The following is a description of a gene set: Genes predicted to be targets of miRBase v22 microRNA mmu_miR_23b_5p in miRDB v6.0 with MirTarget v4 prediction scores > 80 (high confidence targets). Mouse Gene Set: MIR_23B_5P studied in species Mus musculus from publication Chen Y, Wang X (PMID 31504780), and this is the list of marker genes: Mkrn2, Sp7, Gm6710, Sgcd, Nxn, Ifi44, Taf9b, Rbm18, Epb41l5, Ctss, Sat2, Ovgp1, Hbegf, Cdk2ap2, Dsc1, Pcmtd2, Snx30, Pak2, Gnb2, Mrtfb, Rora, Dazap2, Ms4a4b, Sptlc2, Zbtb4, Frmd8, Pde7a, Rp1, Hormad1, Hivep3, Cpne6, Rab39b, Elmod1, Mfap3l, Nrbf2, Hspa12a, Nrip3, Itgav, Med29, Snrpa1, Acot1, Mbtps2, Septin11, Cnot6l, Fbxl17, Hdac2, Stx8, Aif1l, Prrg3, Oxld1, Kif3b, Cdc27, Erich5